Given this list of marker genes TGFBR3, ASS1, NNMT (nicotinamide N-methyltransferase), DCX, LINC00926, SERPINB3, CXCL17, SLC6A15, MAGEA4, FZD8, LAMA1, UPK1B, PROM1, FAM83C (family with sequence similarity 83 member C), GJB2, DYNLRB2, FAM81B, S100A9, ANPEP, TMPRSS3, GRIN2A, LINC01139 (long intergenic non-protein coding RNA 1139), ABI3BP, ABCB1, ACACB, MAP1B, MCOLN3, IL13RA2, MMP28, KRT4, S100A8, SNTN, IGHM, RNF128, CTAG1B, ABCA5, ABCA12 (ATP binding cassette subfamily A member 12), DCBLD1, LCN2 (lipocalin 2), MSLN, C7, GLYATL2, GABRP (NCBI Gene Id 2568), CXCL6, OMG, GREB1, DNAJC6, PDZK1IP1, ACSS3, MFAP5, NLRP7, AADAC, MAMDC2, SERPINA3, FCRL3, SPRR2A, SLC4A4, XIST, PDK4, CFAP263, PDPN, AACSP1, NPY1R, CR2, CEACAM6 (CEA cell adhesion molecule 6), CAPNS2, SCEL, CWF19L2, SERPINB4, CUL9 (NCBI Gene Id 23113), COL27A1, CLIC6, GC, TPD52L1, AHNAK2, PI3, ZG16B, CD72, ALPK2, CCL7, TF, KRT14, ARSD (NCBI Gene Id 414), MPP7, MAGEA3, CD109, KRT24, ZNF322, MMP7, MAP2, PLP1, C19orf33, ZNF204P, SUSD2, CIMIP1, MS4A1 (NCBI Gene Id 931), ELF5, CCDC9B, CHI3L2, CMAHP, KRT23, GSTA1, SERPINA1, PRKCB, PRH1, S100A12, ST6GALNAC5, NTS, MIR142, OLFM4, SPRR3, BICD1, RARRES1, PXDNL, S100A7, PRR4, LINC02397, ITGAL, EFHB, CASP4LP, CXCL5, DNASE1L3 (NCBI Gene Id 1776), SCGB3A1, DMKN, CFAP70, SULT1E1, CFB, PIGR, DOCK5, ST8SIA1, SPMIP6, NQO1, RDH10, TRPM8, SLC6A14, MYBL1, SERTAD4, DEFB1, BTNL9, KRT6B, ANXA8, FBXO2, CLCA2, SLC26A4, SLC6A13, JAML, RORB, BEND7, SPRR1B, HRCT1, S100P, RADX, ART3, CNTNAP3, ICAM4, DNER, CRABP2, UGT2B4, ACSM3, MTERF2, DACH1, TFCP2L1, HAS3, KRT7, RRAD, RAB40B, TCL1A, PROS1, CCDC190, MFAP3L, SPRR1A, GDA, FREM2, MAGEA11, GFOD1, here is a description of the gene set: Genes down-regulated in nasopharyngeal carcinoma (NPC) positive for LMP1, a latent gene of Epstein-Barr virus (EBV). from publication Sengupta S, den Boon JA, Chen IH, Newton MA, Dahl DB, Chen M, Cheng YJ, Westra WH, Chen CJ, Hildesheim A, Sugden B, Ahlquist P (PMID 16912175) To identify the molecular mechanisms by which EBV-associated epithelial cancers are maintained, we measured the expression of essentially all human genes and all latent EBV genes in a collection of 31 laser-captured, microdissected nasopharyngeal carcinoma (NPC) tissue samples and 10 normal nasopharyngeal tissues. Global gene expression profiles clearly distinguished tumors from normal healthy epithelium. Expression levels of six viral genes (EBNA1, EBNA2, EBNA3A, EBNA3B, LMP1, and LMP2A) were correlated among themselves and strongly inversely correlated with the expression of a large subset of host genes. Among the human genes whose inhibition was most strongly correlated with increased EBV gene expression were multiple MHC class I HLA genes involved in regulating immune response via antigen presentation. The association between EBV gene expression and inhibition of MHC class I HLA expression implies that antigen display is either directly inhibited by EBV, facilitating immune evasion by tumor cells, and/or that tumor cells with inhibited presentation are selected for their ability to sustain higher levels of EBV to take maximum advantage of EBV oncogene-mediated tumor-promoting actions. Our data clearly reflect such tumor promotion, showing that deregulation of key proteins involved in apoptosis (BCL2-related protein A1 and Fas apoptotic inhibitory molecule), cell cycle checkpoints (AKIP, SCYL1, and NIN), and metastasis (matrix metalloproteinase 1) is closely correlated with the levels of EBV gene expression in NPC. studied in species Homo sapiens Human Gene Set: SENGUPTA_NASOPHARYNGEAL_CARCINOMA_WITH_LMP1_DN